Given this list of marker genes RASEF, CD47, SERPINB1, SHISA2, ZDHHC7, NAMPT, TRIM16, GATA6, GALNT10, NPAS2, EMB, SESN2, MSX2, SLIT2, EFR3B, SEPSECS, MBOAT2 (NCBI Gene Id 129642), ZNF654, NBEAL1, DCLK1, FZD2, ZNF277 (zinc finger protein 277), DRAM1, PARP9, FAM171B, ME1, KLHL24, RAP1GAP2, CDKN2A, BEX4, PIK3C2B, MYADM, CCDC186, MID1, CCNG2, UBE2H, MAP3K14, LIMA1, ADAM9, CPEB4, GADD45A, RIPK4, TAX1BP1, B4GALT4, ANO6, ABCC3, DIAPH2, TSPAN12, AHNAK2, EGLN3, ERBB2, ITGAV, RND3, EFHD1, PSD3, CD24, TPRG1L, SLC4A7, PALLD, CDH3, ST3GAL1, LIPH, RHOC, TGFBR2, PDLIM1, EFNB2 (NCBI Gene Id 1948), SH3YL1, CRABP2, KIF3A, KLF5, NFKBIZ, PARP12, HPS3, PHLDA3, PDP1, GSTM3, EPB41L2, KDM6A (lysine demethylase 6A), HIVEP2, FBXO32, KIAA1217, FTH1, LYSMD3 (LysM domain containing 3), TMEM30A, CALCOCO1, RASD1, GABBR2, TMEM65, DNAJB2, KLF6, ID3, BCAP29, ADGRF4, CORO2A, SYTL2, PCTP, PHACTR2, AHR, RGL1, PARP8, APPL2, GAREM1, PARP14, ATP6V0A4, BOK, RTL5, BCLAF3, CAB39, KRT80, XRN1, BMF, FBLIM1, ALDH1A3, SNAI2, ARL15, ABCC5, FAM110B, TRA2A, PTGER4, CLDN4 (NCBI Gene Id 1364), UBP1, LPCAT2, ERRFI1, ZNF561, BAK1, RIT1, USP2, DIO2, ITGB6 (NCBI Gene Id 3694), ARL4C, SQSTM1, GSTM2, EPOR, TJP2, ATP10D, MPZL2, CYP1A1, EPB41L5, MYO1E, DDIT3, RND1, CSRP1, TACSTD2, PNRC1, RAB27B, ATP2B1, FZD7, PHLDB1, ACSL3, EFNA1, NECTIN4, CPEB2, FCHO2, SIM2, TCP11L2, FBN2, NCOA7, TRAM2 (NCBI Gene Id 9697), SMYD2, CD55, TAOK3, UACA, CAPN13, NEDD9, AQP3, EPHA4, ANKRD50, DUSP10, MTAP, LAMB1, ST8SIA4, CSRNP1, DSE, IL1R1, UBA5, LMO7, SCHIP1, UBE2J1, MAP4K4, ZBTB37, SLC39A10, FRMD6, KCNJ3, HCAR1, CYRIB, NCF2, GSAP, FHL2, VPS54, CALD1, STAM2, DMRTA1, EGR1, MCL1, SFMBT2, TOM1L2, ETFA, CDK6, ALCAM, PPL, PLA2R1, NBPF8, YPEL5, COQ10B, GAB1, KAT2B, TGFB2, KLHL5, AASS (aminoadipate-semialdehyde synthase), ELMOD2, SYNPO, S100A10, TGFB3, CCSER1, UPK1A, ARID4B, GRAMD2B, NBEA, DUSP4, HES1, COBLL1, TNFRSF21, CNN2, TRAF5, TMEM45B (transmembrane protein 45B), SENP2, DOCK11, TP53INP1, CRISPLD2, ACOX3, MYO6, NTN4, CMYA5, GPR37, TFPI, L1CAM, H4C8, PGM5, ZNF354A, CRIM1, CTNND2, PPP1R3C, SRI, PTPRK, TM4SF1, RFTN1, LHFPL2, ZYX, TFAP2A, DTX3L, TRIB1, DKK1, RCAN1, LFNG, PLK2, PRICKLE1, MGAT4A, EPB41, GDF15, S1PR3, BAZ2B, MOSPD1, BCAS1, GRB7, SH2D4A (SH2 domain containing 4A), SLC9A1, SOX4, CLK1, PAWR, DAB2, PHF20L1, ABCG1, PLIN2, FBXO38, CDKL5, CLDN1, HERC3, MECOM, DZIP3, PPP2R5B, GULP1, MMP16, RNF19A, IGFBP3 (NCBI Gene Id 3486), SEMA7A, SEC62, KIFC3, RAB9A, ENC1, MSRB3, FAM83B, ELF3, ZNF281, ZFP36L1, SGMS2, ARID5B, LMCD1, IRF6, NPHP3, ZDHHC17, LMBRD1, PIK3IP1, ACHE, RBMS1, FERMT2, TP63, SOS2, IFIT1 (interferon induced protein with tetratricopeptide repeats 1), EDN1, PDE9A, TCF7L1, TACC1, ANK3, PPP4R2, NUAK2, WWTR1, TUFT1, STON1, GLIPR2, ABHD4, EPAS1, TGFBI, SASH1, FAM131B, ABCA1, PDE5A, ARAP2 (ArfGAP with RhoGAP domain, ankyrin repeat and PH domain 2), SAMD4A, UBLCP1, RIPOR3, PHLDB2, PIK3R3, LARP6, TLE1, ENTPD3, PAM, IER5, LRIF1 (NCBI Gene Id 55791), DUSP1, ITSN2 (NCBI Gene Id 6454), CCN2, PNPLA8, PACS1, CDYL2, ROCK2, ORMDL3, TNS3, GRB14, SNTB2, MIOS, KDM7A, ACAA2, MAP3K5, HILPDA, TBC1D23, YPEL2, ZKSCAN1, KDM5B, PTPN12, LGALS8, JUNB (NCBI Gene Id 90482), PRSS8, UNC13D, ZNF217, LOXL2, CLDN9, OSGIN2, WWC2, EPHA7, BICDL2, PRR5, SESN3, ABLIM3, PPP1R15B, ACVR1, CDKN2B (cyclin dependent kinase inhibitor 2B), CDKN1A, N4BP3, SLC35A1, VTCN1, MACC1, KYNU, CD46, LRATD1, FN1, CLN8, ACKR3, LDLRAD4, CGN, ANXA3, CDH2, CBLB, CEACAM6, QKI, ZSCAN2, ADGRG6, KDM6B, KIAA0513, ZNF704, ATP1B1, INAVA, ADGRV1, PINK1, TSC22D3, PMEPA1, CDS1, BMP7, EVI5, SH3BGRL2, UGP2, IFIT5, CDC42BPA (CDC42 binding protein kinase alpha), CAST, SH3BP4, KDM3A, KLF3, AKIRIN2, OPTN (optineurin), DBN1, FAT4, ZNF117, SERTAD4, ANOS1, LYST, SKIL, PDLIM5, NEDD4L, CITED2, TRIM5, OFD1, MME, PCDH9, TPM4, ZNF12, GUCY1A2, SLC31A2, ITGB8 (integrin subunit beta 8), CAMK2N1, SOCS2, MARCKS, ARHGAP12, SMAD3, TAGLN, GRAMD1A, LIMCH1 (NCBI Gene Id 22998), CYB5R1, IL13RA1, EXT1, MCCC1, PPP3CC, TMPRSS2, DNAJC22, BLTP1, CREB3L2, MATN2, IFNGR1, FBN1, BASP1 (brain abundant membrane attached signal protein 1), ABCG2, LRRC1, BCKDHB, MYL12A, UGT1A6, SCN1B, MAP3K8, DNAJC15 (DnaJ heat shock protein family (Hsp40) member C15), JUN, GOLGA4 (golgin A4), CTSH, SLCO2A1, DDX60, DDIT4, MYH9, STK38L, RWDD2A, ARHGAP5, PLEKHF2, DAPK3 (death associated protein kinase 3), MYO1B, SALL4, MTCL1, SYDE2, PPARG, HBP1, CCNDBP1, FNBP1L, HOXC13, LNX1, ANXA2, SLC17A5, RAPGEF2, BTG2, RNF144B, ATP8A1, PGM2L1, RPS6KC1, EXOC6B, GRHL3, FRAS1, MAOA, CREBRF, PCDH1, NUAK1, MAP2, here is a description of the gene set: studied in species Homo sapiens from publication Dutertre M, Gratadou L, Dardenne E, Germann S, Samaan S, Lidereau R, Driouch K, de la Grange P, Auboeuf D (PMID 20406972) Human Gene Set: DUTERTRE_ESTRADIOL_RESPONSE_24HR_DN Alternative promoters (AP) occur in >30% protein-coding genes and contribute to proteome diversity. However, large-scale analyses of AP regulation are lacking, and little is known about their potential physiopathologic significance. To better understand the transcriptomic effect of estrogens, which play a major role in breast cancer, we analyzed gene and AP regulation by estradiol in MCF7 cells using pan-genomic exon arrays. We thereby identified novel estrogen-regulated genes (ERG) and determined the regulation of AP-encoded transcripts in 150 regulated genes. In <30% cases, APs were regulated in a similar manner by estradiol, whereas in >70% cases, they were regulated differentially. The patterns of AP regulation correlated with the patterns of estrogen receptor alpha (ERalpha) and CCCTC-binding factor (CTCF) binding sites at regulated gene loci. Interestingly, among genes with differentially regulated (DR) APs, we identified cases where estradiol regulated APs in an opposite manner, sometimes without affecting global gene expression levels. This promoter switch was mediated by the DDX5/DDX17 family of ERalpha coregulators. Finally, genes with DR promoters were preferentially involved in specific processes (e.g., cell structure and motility, and cell cycle). We show, in particular, that isoforms encoded by the NET1 gene APs, which are inversely regulated by estradiol, play distinct roles in cell adhesion and cell cycle regulation and that their expression is differentially associated with prognosis in ER(+) breast cancer. Altogether, this study identifies the patterns of AP regulation in ERGs and shows the contribution of AP-encoded isoforms to the estradiol-regulated transcriptome as well as their physiopathologic significance in breast cancer. Genes down-regulated in MCF7 cells (breast cancer) at 24 h of estradiol treatment.